Given this list of marker genes Hdac2 (NCBI Gene Id 28131), Hdac1, Hdac3, Hdac8, Sirt1, here is a description of the gene set: Mouse Gene Set: GOMF_HISTONE_DECROTONYLASE_ACTIVITY Catalysis of the reaction: H2O + N6-(2E)-butenoyl-L-lysyl- = (2E)-2-butenoate + L-lysyl-. studied in species Mus musculus